The following is a description of a gene set: Reactome Pathway: Killing mechanisms studied in species Homo sapiens The long-lasting Leishmania infection is established within macrophages in which the most effective killing response is the production of reactive oxygen species (ROS) and reactive nitrogen species (RNS).. Additionally, autophagy has been described as an innate immune mechanism for eliminating intracellular pathogens, although its role in restricting Leishmania replication is unclear part of: Leishmania infection, and this is the list of marker genes: NOXA1, RAC1, WNT5A, NOX1, CYBA, DVL2, DVL3, NOXO1, FZD7, MAPK8, JUN, DVL1